Given this list of marker genes PBOV1, LHX6, ZDHHC14, SLC26A3 (solute carrier family 26 member 3), CAMK4, SCN10A, THPO, PCDH7, ALDH1L1, FBLN1, PAMR1, FZD9, EGOT, B4GALNT1, CAPN6, HSPA12A, CHRM5, SLC6A20, PRAMEF12, CASR, KIF21B, CCDC70, GP9, RPS6KA4, KCNAB3, FUT6, SARM1, RS1, PDHA2, GRP (gastrin releasing peptide), STAB2, FEZ1, QPCTL, RHD, PPEF1, RAD54L, THRB, OR10H2, LRRC32, PGR, ANGPT1, PEX5L, CDH3, ERICH1, PRL, LDHC, ADAM5, ARPP21, SHOX, OBSL1, WNT6, GDF9 (NCBI Gene Id 2661), ART1, EPS8L3, GJC1, KCNJ3, NEUROG2, FANCC (NCBI Gene Id 2176), POU5F1P4, SMPX, DELEC1, PPBPP2, HAND1, KCNJ9, HAVCR1, GNG4, ATP12A, BICC1, SLC49A3, COL5A1, ZNF287, ATP2B3, F2RL1, COBL, SCN2A, SLC5A7, CST8, SALL2, STRA6, SLC12A5, ANGPTL2, IL1RAPL2, DNAAF1, ACHE, CIDEC, LINC01587, TAPT1, COX7A1, NRSN2, MYO19, PLG, ASF1B, PDE12, PTPRT, ARHGEF10, PCBP4, ATRNL1, CRISP1, PDE6C, PACRG, RDH16, LIM2, NUP93, PPP2R2B, IL13RA2, IL12RB1, SPIN2A, MPP2, C8B, FGA (fibrinogen alpha chain), HFE, SORBS2, VSTM4, PDLIM4, TNFRSF4, KRT5, TRH, MYOC, FLRT1, AATK, ADRA2A, PRG3, ATXN7L1 (ataxin 7 like 1), TSHB, TLE2, IFNA6 (NCBI Gene Id 3443), ODF1, CAP2, RAMP3, GH2, TCP11L1, ASH2L, TCP11, TNR, KIR2DL5A, TRIM2 (tripartite motif containing 2), DPP6, IL17RC, PPP1R14D, NRL, TRIM29, UMOD (uromodulin), LINC00574, DEFB4A, PDE11A, PPBP, CYP2F1 (NCBI Gene Id 1572), HSD17B2, DEFA5, PRDM9, SYT12, TEAD4, IHH, CNTN1 (NCBI Gene Id 1272), RUNX1T1, GPR37, SYBU, ABCC6, GYG2, HIGD1B, GFRA4, ACTG1, AMN, GPR50, LUC7L, NAB2, CLEC5A, DEFA6, ERBB2, SLC6A13, FZD4, CLEC1B, SLC4A3, AIRE, KCNQ2, KRT23, CELA3A, KCNV1, SORCS3, CCL1, KCNJ13, NEK11, ECE2, TGM3, TFAP2C, RASL10A, UBE2D4, FGF23, NPFFR1, KLK12, CSN3, NEUROD2, MYO6, BBC3, SEMA3F, ITIH4, here is a description of the gene set: Interaction of hematopoietic progenitors with the thymic stromal microenvironment induces them to proliferate, adopt the T cell fate, and asymmetrically diverge into multiple T lineages. Progenitors at various developmental stages are stratified among different regions of the thymus, implying that the corresponding microenvironments differ from one another, and provide unique sets of signals to progenitors migrating between them. The nature of these differences remains undefined. Here we use novel physical and computational approaches to characterize these stromal subregions, distinguishing gene expression in microdissected tissues from that of their lymphoid constituents. Using this approach, we comprehensively map gene expression in functionally distinct stromal microenvironments, and identify clusters of genes that define each region. Quite unexpectedly, we find that the central cortex lacks distinctive features of its own, and instead appears to function by sequestering unique microenvironments found at the cortical extremities, and modulating the relative proximity of progenitors moving between them. studied in species Homo sapiens Human Gene Set: GSE18281_CORTICAL_THYMOCYTE_VS_WHOLE_CORTEX_THYMUS_UP from publication Griffith AV, Fallahi M, Nakase H, Gosink M, Young B, Petrie HT (PMID 20064453) Genes up-regulated in cortical thymocytes versus thymus whole cortex.